The following is a description of a gene set: Enables the transfer of ATP, adenosine triphosphate, from one side of a membrane to the other. studied in species Mus musculus Mouse Gene Set: GOMF_ATP_TRANSMEMBRANE_TRANSPORTER_ACTIVITY, and this is the list of marker genes: Slc25a31, Slc25a54, Slc25a23, Slc25a4, Slc25a24, Ank (NCBI Gene Id 52488), Slc35b1, Slc17a9 (NCBI Gene Id 71857), Slc25a5, Slc25a42, Panx1, Slc25a41, Slc25a17, Slc25a25